The following is a description of a gene set: Reactome Pathway: Negative regulation of NMDA receptor-mediated neuronal transmission studied in species Homo sapiens The duration of NMDA receptor-mediated neuronal transmission can be limited by binding of the activated calmodulin to the activated NMDA receptor. In addition to shortening the NMDA channel pore open state, calmodulin interferes with ACTN2-mediated anchoring of NMDA receptors to the postsynaptic density. Protein phosphatases PPM1E and PPM1F dephosphorylate activated calcium/calmodulin-dependent kinases (CaMKs), thus halting CaMK-mediated signaling (Ishida, Okuno et al. 1998, Ishida et al. 1998, Kitani et al. 2003). part of: Activation of NMDA receptors and postsynaptic events, and this is the list of marker genes: PPM1E, CAMK2B, GRIN2D, CAMK4, GRIN2C, NEFL, CALM1, ACTN2, CAMK1, DLG2, CAMK2G, DLG1, DLG4, LRRC7, PPM1F, GRIN2B, CAMK2D, CAMK2A, GRIN2A, DLG3, GRIN1